Given this list of marker genes GREM1, RASSF2, UBASH3B, TPH1, IL20RA, ADRB2, NOTCH2, LTBP3, BGLAP (bone gamma-carboxyglutamate protein), TNFRSF11A, GDF5, CTHRC1, LRP5, MITF (NCBI Gene Id 7487), HTR1B, RAB7A (RAB7A, member RAS oncogene family), PTH, TNFSF11, ARAP1, ADAM8, ACP5, SPP2, SNX10, CARTPT, CTSK, TMEM119, BBLN, IHH, GPR137B, SYK, LEP, PTN, EXT1, WNT16, ZNF675, EPHA2, RAB3D, PTH1R, P3H4, SIGLEC15, LRRK1, LGR4, DEF8, GJA1, RAC2 (Rac family small GTPase 2), TCIRG1, PDK4, NF1, RUFY4, SLC4A2, IL7, CSK (C-terminal Src kinase), LEPR, FSHB, HERC1, TNFAIP3, DOCK5 (dedicator of cytokinesis 5), DCSTAMP, TRAF6, EFNA2, SPP1, SFRP1, PRKCA (NCBI Gene Id 5578), NOX4, PTK2B, INPP5D, ITGB3, CD38, P2RX7, S1PR1, FSHR, CSF1R, NCDN (neurochondrin), GPR137, CALCA, MDK, CLDN18 (NCBI Gene Id 51208), IL6 (interleukin 6), CTNNB1, TPP1, SUCO, SYT7, IAPP, PLEKHM1, MC4R, TMEM64, SRC, GPR55, here is a description of the gene set: species: Homo sapiens The continuous turnover of bone matrix and mineral that involves first, an increase in resorption (osteoclastic activity) and later, reactive bone formation (osteoblastic activity). The process of bone remodeling takes place in the adult skeleton at discrete foci. The process ensures the mechanical integrity of the skeleton throughout life and plays an important role in calcium homeostasis. An imbalance in the regulation of bone resorption and bone formation results in many of the metabolic bone diseases, such as osteoporosis. Human Gene Set: GOBP_BONE_REMODELING